Given this list of marker genes PDHA2, PDHA1, DLD, DLAT, PDHB, PDHX, here is a description of the gene set: Catalysis of the oxidative decarboxylation of pyruvate. studied in species Homo sapiens Human Gene Set: GOMF_PYRUVATE_DEHYDROGENASE_ACTIVITY